The following is a description of a gene set: Any process that results in a change in the behavior of an organism as a result of a nicotine stimulus. species: Homo sapiens Human Gene Set: GOBP_BEHAVIORAL_RESPONSE_TO_NICOTINE, and this is the list of marker genes: CHRNA5, CHRNA4, CHRNB2, CHRNA3, CHRNB1, CHRNB4, PPARA, CHRNA6, GRM2